Given this list of marker genes ATP1A2, CACNA1A, PRRT2, CLTCL1, SCN1A, here is a description of the gene set: Human Gene Set: HP_SEESAW_NYSTAGMUS Seesaw nystagmus is a type of pendular nystagmus where a half cycle consists of the elevation and intorsion of one eye, concurrently with the depression and extortion of the fellow eye. In the other half cycle, there is an inversion of the ocular movements. species: Homo sapiens Seesaw nystagmus